Given this list of marker genes SKIL, ING2, LATS2, HDAC1, NF1, TEAD3, TEAD1, SATB2, TEAD4, TEAD2, LATS1, SIN3A, HDAC3, STK3, SKI, MERTK, MECP2, PRMT5, here is a description of the gene set: Transcription co-factors SKI and SKIL protein partners Human Gene Set: WP_TRANSCRIPTION_COFACTORS_SKI_AND_SKIL_PROTEIN_PARTNERS studied in species Homo sapiens